Given this list of marker genes IDH1, here is a description of the gene set: studied in species Homo sapiens Reactome Pathway: Abnormal conversion of 2-oxoglutarate to 2-hydroxyglutarate part of: Diseases of metabolism Somatic mutations affecting arginine residue 132 of IDH1 (isocitrate dehydrogenase 1, a cytosolic enzyme that normally catalyzes the NADP+-dependent conversion of isocitrate to 2-oxoglutarate), are very commonly found in human glioblastomas. These mutant proteins efficiently catalyze the NADPH-dependent reduction of 2-oxoglutarate to form 2-hydroxyglutarate. Cells expressing the mutant protein accumulate elevated levels of 2-hydroxyglutarate, probably in the cytosol as IDH1 is a cytosolic enzyme. The fate of the 2-hydroxyglutarate is unclear, but the high frequency with which the mutation is found in surveys of primary tumors is consistent with the possibility that it is advantageous to the tumor cells.